Given this list of marker genes JAG1 (NCBI Gene Id 3715), TGFBR1, TGFB2, EMP2, NOTCH1, TWIST1, ACVR1, ENG, TGFBR2, here is a description of the gene set: Human Gene Set: GOBP_POSITIVE_REGULATION_OF_CARDIAC_EPITHELIAL_TO_MESENCHYMAL_TRANSITION species: Homo sapiens Any process that starts or increases the rate, frequency or extent of cardiac epithelial to mesenchymal transition, a transition where a cardiac epithelial cell loses apical/basolateral polarity, severs intercellular adhesive junctions, degrades basement membrane components and becomes a migratory mesenchymal cell.